The following is a description of a gene set: Human Gene Set: WP_GLUCOCORTICOID_BIOSYNTHESIS Glucocorticoid biosynthesis studied in species Homo sapiens, and this is the list of marker genes: AKR1C3, AKR1C1, CYP11B2, CYP3A4, CYP11B1, CYP21A2, SRD5A1, SRD5A2, AKR1C2, CBR1, AKR1D1 (NCBI Gene Id 6718), HSD11B2, HSD11B1, AKR1C4